The following is a description of a gene set: studied in species Homo sapiens The series of events required for an organism to receive a sensory chemical stimulus, convert it to a molecular signal, and recognize and characterize the signal. This is a neurological process. Human Gene Set: GOBP_SENSORY_PERCEPTION_OF_CHEMICAL_STIMULUS, and this is the list of marker genes: TAS2R7, OR52B6, OR3A1, OR9A1P, OR12D2, OR51E2 (olfactory receptor family 51 subfamily E member 2), OR9G9, OR1N2, OR11L1, OR52I1, OR9A2, OR5M8, OR7G3, OR2L5, OR2T5, OR5AK3P, OR1N1, TAS2R1, OR51B6, OR1J4, OR5AU1, OR4B1, TAAR5, OR4F3, OR2L2, OR52P1, P2RX3 (NCBI Gene Id 5024), BBS1, NAV2, CALHM3, CALHM1, OR10X1, OR1K1, OR56A1 (olfactory receptor family 56 subfamily A member 1), OR10K2, OR52R1, P2RX2, OR7A17, OR1L3, OR1B1, OR1J1, OR2G6, ADCY3, OR5AK2, OR8J2, OR13C4, OR1S1, OR6Y1, OR52Z1P, OR2M3, TAS2R43, OR2T10, OR2W6P, OBP2A, TAAR6, OR2A2, OR10D4P, OR52L2P, SYT10 (synaptotagmin 10), OR2A14, TRPA1, OR4N5, OR6K2, OR52A1, OR5P3, OR52E6, LEF1, OR1F12P, OR2F2, ANO9, OR6K3, OR52E4, SCNN1A, TAS2R10, TAS2R31, OR4D11, TAS2R40, PLCB2, GNB1, OR6C2, RGS21, OR8K3, OR8B4, OR10H1, OR5H2, OR2AG1, OR51B5, OR52K2, TAS2R5 (taste 2 receptor member 5), OR2AP1, OR13C7 (NCBI Gene Id 81377), OR5T1, OR4C5, CNGA4, OR13G1, OR4C13, OR5M11, OR5L2, OR2D2, OR6K6, OR4C3, OR51B4, UBR3, OR2T8, OR8J3, OR3A2, OR6B1, GNAT1, OR8D4, OR8D2, OR9Q2, NXNL2, TTC8, TAAR3P, OR6C4, OR14A16, OR8B3, OR2W3, OR4K3, TAS2R19, OR9I1, OR2B3, OR5B2, OR2AE1 (NCBI Gene Id 81392), OR2Z1, OR52L1, RTP4, OR51V1, OR1E3, SCNN1B, OR5C1, OR2T29, RIC8B, GNAS, OR5M10, OR5K3, OR4Q3, TAAR9, OR4D2, OR1I1, OR10H4, OR56A3, OR4D9, OR2Y1, CST1, UGT2A1, OR8U3, OR5M9, OR51F1, OR10AC1, OR1E1, OR2I1P, GPR148, OR2T27, OR5K1, TAS2R38, TAS2R20, OR6P1, TAS2R8, OR51I1, SLC6A3, OR5D16, VN1R17P, OR14I1, GNAT3, OR6T1, OR2J1, OR2A7, OR4F6, TAS2R46, OR10S1, SLC24A4, OR2M2, TAS2R30, OR10AG1, CST2, OR2B6, OR4F29, SCNN1D (sodium channel epithelial 1 subunit delta), OR10G8, OR8H3, OR4L1, OR10G2, OR1D2, OR2A4 (NCBI Gene Id 79541), OR5AP2, OR5H14, OR10A6, B3GNT2, WNT10B, OR51J1, OR2T35, OR2V1, OR4F5, OR10A4, VN1R2, OR4M2B, OR4P4, OR6C3, OR4M2, OR5BS1P, OR4C11, OR5V1, OR2C1, OR2B11, OR2T11, OR6S1, OR51F2, OR5F1, OR12D3, OR2M4, OR2K2, OR2T33, OR4D1, OR4A16, OR52A5, OR1A2, OR51M1, OR1S2, OR1J2, OR4A47, OR6F1, OR6C75, OR4S2, OR6C68 (olfactory receptor family 6 subfamily C member 68), OR5D14, OR4C16, OR10Z1, OR9G1, OR13J1, OR10H3, OR10A2, OR5P2, OR10AD1, OR52E2, OR4A15, OR5H6, OR2T6, OR1P1, OR52K1, OR2L3, OR51H1, OR6Q1, OR52W1, OR10G9, TAS1R2, OR56A4, OR6B2, OR8J1, OR5AC2, OR10W1, OR6N2, TAS2R3, OR2J3, OR11A1, OR5I1, GNAT2, OR10G6, OR1D5, OR4F17, OR1M1, OR7G2, TAS2R16, OR51A4, CA6, OR2T4, OR8B2, OR4K15, OR2AT4, OR8A1, OR8K1, OR4E1, OR2F1, OR5AC1, LPO, OR52H1, OR2A25, PDE4A, CD36, OR5AS1, OR13C6P, OR52E5, OR5H8, OR5A2, TAS1R1, OR1G1, OR14L1, OR4A5, OR5J2, OR4K14, FFAR4, OR4D10, OR4Q2, OR51A2, OR2J2, OR8S1, OR51T1 (NCBI Gene Id 81275, olfactory receptor family 51 subfamily T member 1), GNG13, OR4S1, OR2G2, TAS2R13, OR13H1, OR10J6P, OR14J1, PKD2L1, OR14K1, OR51G2, OR5G3, OR1L6, GFY, OR52B2, OR56A5, FZD2, OR2B8P, OR4M1, OR4E2, OR6M1, B2M, OR5AN1, OR4A4P, OR11H4, OR2L8, OR4F15, OR2W1, OR5B3, OR1A1, TAS1R3, OR4C45, OR52N5, OR13C3, OR7A10, ASIC1, OR6X1, PIGR, OR5B21, OR7C2, OR4N4, OR4C6, OR13F1, OR10P1, OR5D13, VN1R4, OR51S1, OR1F1, OR9A4, MKKS, OR51D1 (olfactory receptor family 51 subfamily D member 1), OR2B2, OR51G1, OR8D1, OR6B3, OR2AJ1, OR10R2, TAS2R60, OR4F4, OR8U1, TAS2R50, OR8I2, OR51I2, OR9G4, OR2T7, OR4K1, OR5K2, OR8H1, TAS2R39, OR9Q1, OR8G5, CST4, OR56B1, OR13D1, OR14C36, OR10D3, OR2M7 (olfactory receptor family 2 subfamily M member 7), OR10H5, TAS2R4 (taste 2 receptor member 4), OR4C46, OR11H6 (NCBI Gene Id 81131), OR5AL1, OR4F16, OR56B4, OR13C5, OR6J1, OR5M3, OR4X2, TAS2R42, OR2A1, OR2H1, TAS2R14, ITPR3, OR7G1, OR5L1, OR6A2, OR52D1, OR10C1, OR6C1, OR12D1, OR56B2P, OR7C1, OMP, OR10J1, RTP3, OR2T2, OR8B8, OR52E1, OR6C76, OR4X1, OR5T2, OR11G2, OR10H2, OR11H12, VN1R1, OR52B4, SCNN1G, OR5K4, OR5AR1, OR1Q1, BEST2, OR2W5P, OR52A4P, ASIC2, OR8U9, OR8K5, OR1C1, CNGA2, ASIC3, OR10G4, OR6C6, TRPV1, OR4F21, OR13A1, CFAP69, OR3A3 (olfactory receptor family 3 subfamily A member 3), OR2M5, C5AR1, OR14A2, OR7A5, OR8H2, OR6C70, RTP2, OR11H7, OR7A2P, OR51L1, CNGB1, OR13C9, OR8G3P, OR5W2, DRD2, OR5M1, OR4D5 (NCBI Gene Id 79474), OR2T34, OR10G7, OR51A7, OR2H2, PKD1L3, OR8G1, OR51C1P, OR2A5, OR10G3, OR52N2, OR7E24, OR2A12, OR1L8, OR6V1, OR2D3, OR7D4, OR4N2, OR10A7, OR10J3, OR10V1, OR2V2, RTP5, OR51E1, OR4A8, OR11H2, OR1E2, OR52M1, OR2T3, OR10J5, OR5D18, OR5H15, OR8B12, OR2G3, OR2AK2, OR2S2, OR8U8, OR9K2, OR4K17, OR2AG2, OR4C15, OR8G2P, OR5B17, TAS2R9, OR6C74, AZGP1, VN1R3 (NCBI Gene Id 317702), OR10A5, OR1D4, TAS2R45, OR4C12, OR5H1, OR2C3, OR51B2, PIP, OR52N1, OR2A42, OR4K2, OR1L1, OR51Q1, OR11H1, OR10K1, OR2T1, OR4K13, OR5T3, OR13C2, RTP1 (NCBI Gene Id 132112), OR6N1, OR52E8, OR2L13, OR5B12, OR10J4, OBP2B, OR1F2P, TAS2R41, BBS4, OR6C65, REEP2, OR2T12, OR52J3 (NCBI Gene Id 79527), OR13C8, OR10Q1 (NCBI Gene Id 81346), OR4K5, GJB4, OR10T2, OR4D6, OR10A3, OR1L4, OR52I2, OR7D2, OR5A1, GNAL, LCN1, OR52N4